The following is a description of a gene set: species: Homo sapiens Human Gene Set: MIR7851_3P Genes predicted to be targets of miRBase v22 microRNA hsa-miR-7851-3p in miRDB v6.0 with MirTarget v4 prediction scores > 80 (high confidence targets). from publication Chen Y, Wang X (PMID 31504780), and this is the list of marker genes: RB1, SREK1 (NCBI Gene Id 57833), SERPINA9 (serpin family A member 9), AK2, OGT, WDR6, UGT3A1, RTL6, GFOD2, CAPZA1, SMU1, EDEM3, LHX8, ZNF814 (zinc finger protein 814), MBD6, JADE2, SF3A3, CNPPD1, CYP1A1, RNF144A, PHIP, SV2C, BRPF3, E2F2, UGDH (NCBI Gene Id 7358), PPP1R1A, PYM1, SLC38A1, YPEL5, FOXJ1, BOD1L2, HIP1, BMP8A, COX15, STX6, TSPAN33 (NCBI Gene Id 340348), NFKBIZ, SCN4B, TCF4 (transcription factor 4), TNFAIP2 (NCBI Gene Id 7127), LUC7L, BOK, GPCPD1, ATG5, SLCO2B1, NCBP3, CYTH3, CACFD1, RCCD1, CENPU, AP3S1, TRIM47, C14orf28, ELMOD1, RARA, ABL2